The following is a description of a gene set: studied in species Mus musculus The process of negative regulation of cell adhesion that results in a cell or sheet of cells splitting off from an existing epithelial sheet. Mouse Gene Set: GOBP_DELAMINATION, and this is the list of marker genes: Cdsn, Akna, Trpv4 (NCBI Gene Id 80591), Spi1, Mettl3, Ythdf2, Abca12, Specc1l